The following is a description of a gene set: Mouse Gene Set: REACTOME_RESPIRATORY_ELECTRON_TRANSPORT studied in species Mus musculus Respiratory electron transport, and this is the list of marker genes: Ndufa11, Cox7c, Lyrm7, Got1, Cox4i1, Uqcrb, Iscu, Acad9, mt-Nd3, Ndufc1, Uqcrq, Fxn, Cox7a2, Mdh1 (NCBI Gene Id 83566), Pyurf, Etfdh, mt-Nd4, Cox16, Cycs, Ndufa7, Cox6c, Uqcrfs1, Ndufb4, Ndufaf2, Cox11, Ndufs1, Ndufb10, Cox17, Ndufa10, Ndufa3, Tmem126b, Coq10b, Gm10053, Cox19, mt-Nd2, Ndufb1, Ndufs7, Timm21, Slc25a12, Hscb, Ndufb6, Ndufa2, Coa3, Ndufaf5, Cox20, Ndufa13, Got2, Ndufb2, Ndufa5, Cox5a, Nubpl, Ndufs6, Ndufb3, Sco2 (NCBI Gene Id 100126824), Uqcrh, Cox6a1, Higd1c, Ttc19, Ndufa6, Cox7a1, mt-Nd6, Ndufa1, Lyrm2, Cox5b, mt-Nd1, Ndufs8, Uqcr10, Ndufa9, Hccs, mt-Co1, Cox6a2, Dmac1, Ndufb7, Ndufs2, Ndufb9, Ndufaf4, Slc25a13, Ndufb11, Sco1, Higd1a, Ndufc2, Timmdc1, Uqcrc1, Cox7b, Cox8c, Cox15, Lyrm4, Surf1, Ndufaf1, Dmac2, Ndufa4, Ndufa12, Cox4i2, Cmc1, mt-Co3, Uqcrc2 (ubiquinol cytochrome c reductase core protein 2), Ndufv3, Cox7a2l, Etfb, mt-Cytb, Ndufb8, Ndufab1, Ndufaf6, Slc25a18, Coa5, Ndufaf3, Ndufa8, Cox14, Ndufv1, mt-Nd5, Nfs1, Tmem186, Smim20, Cyc1, Higd2a, Ndufv2, Etfa, Hspa9, Slc25a11, Tmem177, Cox18, Cox6b1, Rab5if, Cox6b2, mt-Co2, Mdh2, Cox8a (cytochrome c oxidase subunit 8A), Ndufb5 (NADH:ubiquinone oxidoreductase subunit B5), Ecsit, Ndufs4, Ndufaf8, Ndufs5, Slc25a22, Coq10a, Ndufs3, Ndufaf7